The following is a description of a gene set: Reactome Pathway: Biosynthesis of maresin conjugates in tissue regeneration (MCTR) Resolution of inflammation is carried out by endogenous mediators termed specialised proresolving mediators (SPMs). Macrophages are central to the acute inflammatory response, governing both initiation and resolution phases, depending on the macrophage subtype activated. Human macrophages involved in resolution produce a family of bioactive peptide-conjugated mediators called maresin conjugates in tissue regeneration (MCTR). These mediators stimulate human phagocytotic functions, promote the resolution of bacterial infections, counterregulate the production of proinflammatory mediators and promote tissue repair and regeneration. The proposed biosynthetic pathway is as follows. The maresin epoxide intermediate 13(S),14(S)-epoxy-MaR (13(S),14(S)-epoxy-docosahexaenoic acid) can be converted to MCTR1 (13(R)-glutathionyl, 14(S)-hydroxy-docosahexaenoic acid) by LTC4S and GSTM4. MCTR1 can be converted to MCTR2 (13(R)-cysteinylglycinyl, 14(S)-hydroxy-docosahexaenoic acid) by γ-glutamyl transferase (GGT). Finally, a dipeptidase can cleave the cysteinyl-glycinyl bond of MCTR2 to give MCTR3 (13(R)-cysteinyl, 14(S)-hydroxy-docosahexaenoic acid). species: Homo sapiens part of: Biosynthesis of DHA-derived sulfido conjugates, and this is the list of marker genes: GSTM4, LTC4S